The following is a description of a gene set: Any process that results in a change in state or activity of a cell (in terms of movement, secretion, enzyme production, gene expression, etc.) as a result of an electrical stimulus. Human Gene Set: GOBP_CELLULAR_RESPONSE_TO_ELECTRICAL_STIMULUS studied in species Homo sapiens, and this is the list of marker genes: REST (RE1 silencing transcription factor), PTEN, SLC9A1, NSMF, CALR, GRM1, ADSS2, NEUROD2 (neuronal differentiation 2), HPCA, ADSS1, PALM, GNAT1